The following is a description of a gene set: studied in species Homo sapiens Human Gene Set: GOBP_AIM2_INFLAMMASOME_COMPLEX_ASSEMBLY The aggregation, arrangement and bonding together of a set of components to form the AIM2 inflammasome complex., and this is the list of marker genes: PYDC5, GBP2, IFI16, AIM2, GBP5, CASP1, TRIM11